The following is a description of a gene set: Negative Elastic Net coefficient component of Forty-eight genes properly discriminating severe from mild evolution of COVID-19 pneumonia in the validation cohort (Elastic Net-penalized linear model). studied in species Homo sapiens COVID-19 is associated with heterogeneous outcome. Early identification of a severe progression of the disease is essential to properly manage the patients and improve their outcome. Biomarkers reflecting an increased inflammatory response, as well as individual features including advanced age, male gender, and pre-existing comorbidities, are risk factors of severe COVID-19. Yet, these features show limited accuracy for outcome prediction. The aim was to evaluate the prognostic value of whole blood transcriptome at an early stage of the disease. Blood transcriptome of patients with mild pneumonia was profiled. Patients with subsequent severe COVID-19 were compared to those with favourable outcome, and a molecular predictor based on gene expression was built. Unsupervised classification discriminated patients who would later develop a COVID-19-related severe pneumonia. The corresponding gene expression signature reflected the immune response to the viral infection dominated by a prominent type I interferon, with IFI27 among the most over-expressed genes. A 48-genes transcriptome signature predicting the risk of severe COVID-19 was built on a training cohort, then validated on an external independent cohort, showing an accuracy of 81% for predicting severe outcome. These results identify an early transcriptome signature of severe COVID-19 pneumonia, with a possible relevance to improve COVID-19 patient management. Human Gene Set: ARMIGNACCO_SEVERE_COVID19_RISK_EN_NEG from publication Armignacco R, Carlier N, Jouinot A, Birtolo MF, de Murat D, Tubach F, Hausfater P, Simon T, Gorochov G, Pourcher V, Beurton A, Goulet H, Manivet P, Bertherat J, Assié G, COVIDeF group (PMID 38772950), and this is the list of marker genes: CASS4, KNDC1, MRAS, PGA3, NEURL1, TNFRSF9, CACNA2D3, ARPIN, ADGRD1, LKAAEAR1, TPPP3, GOLGA8B, PID1, MS4A14, CHRM3-AS2, OLFM1, ZNF703, SUSD4, VN1R1, ADGRE4P, RTN1, DYRK2, EFCAB14, ZDHHC1, ZNF469, LINC01891, MTX3